The following is a description of a gene set: Any process that activates or increases the frequency, rate or extent of the phosphorylation of peptidyl-serine. Mouse Gene Set: GOBP_POSITIVE_REGULATION_OF_PEPTIDYL_SERINE_PHOSPHORYLATION studied in species Mus musculus, and this is the list of marker genes: Gsk3a, Egfr, Wnt5a, Oprd1, Arrb2, Rptor, Il6, Smyd3, Avp, Prkd1, Trim6, Eif4g1, Braf, App, Akap9, Mif (macrophage migration inhibitory factor (glycosylation-inhibiting factor)), Met, Akt1 (thymoma viral proto-oncogene 1), Nrxn1, Stk4, Araf, Ip6k2, Mapkap1, Tek, Crebl2, Fnip1, Phip, Stox1, Ercc6, Igtp, Pfn2, Hdac6, Pink1 (NCBI Gene Id 68943), Osm, Ret, Cd44, Ripk2, Cav1, Wnt3a, Ucn, Ntf3, Irgm1, Bdnf, Lif, Raf1, Bcl2, Txn1, Ifnb1, Irgm2, Cnot9, Bag4, Dock7, Tnf, Akt2, Ifng, Nos1, Tnks1bp1, Isl1, Angpt1, Ntrk2, Bcar3, Tfrc, Il11, Ntrk3, Park7, Spry2, Fnip2, Pdcd10, Tenm1, Lats1, Agt, Mad2l2, Pak1